The following is a description of a gene set: Cytokines mediate cell-cell communication in the immune system and represent important therapeutic targets. A myriad of studies have highlighted their central role in immune function, yet we lack a global view of the cellular responses of each immune cell type to each cytokine. To address this gap, the authors created the Immune Dictionary, a compendium of single-cell transcriptomic profiles of more than 17 immune cell types in response to each of 86 cytokines (>1,400 cytokine-cell type combinations) in mouse lymph nodes in vivo. A cytokine-centric view of the dictionary revealed that most cytokines induce highly cell-type-specific responses. For example, the inflammatory cytokine interleukin-1β induces distinct gene programmes in almost every cell type. A cell-type-centric view of the dictionary identified more than 66 cytokine-driven cellular polarization states across immune cell types, including previously uncharacterized states such as an interleukin-18-induced polyfunctional natural killer cell state. studied in species Mus musculus from publication Cui A, Huang T, Li S, Ma A, Pérez JL, Sander C, Keskin DB, Wu CJ, Fraenkel E, Hacohen N (PMID 38057668) Genes negatively differentially expressed in cell type: CD4+ T cell upon treatment with cytokine: IL-1β in mouse lymph nodes in vivo. Mouse Gene Set: CUI_T_CELL_CD4_IL1B_RESPONSE_DN, and this is the list of marker genes: Capg, Fam78a, Ass1, Bcl11b, Bin2, Adgre5 (adhesion G protein-coupled receptor E5), Tesc, Cnn2, Cd40lg, Pycard, Shisa5, Rasgrp1, Thy1, Srpk2, Dap, Stap1, Myl6, Tbc1d10c, Dipk1a, Tecpr1, Selenop, Ptprcap, Pdk1, Tox, Sh3kbp1, Rab37, Fmnl1, Filip1l, Lck, Cd6, Zbtb7b, Foxp1, Itgal, Hsd11b1, Prex1, Adcy7, Akr1b1, Smc4, Tspan32, Rgcc, St8sia6 (NCBI Gene Id 99126, ST8 alpha-N-acetyl-neuraminide alpha-2,8-sialyltransferase 6), Lcp1, Sh3bgrl3, Tagln2, Emp3, Saraf, Ramp1, 9930111J21Rik2, Mgst2, Cd96, Crip1, Lgals1, Evl, Tnik, Grap, Septin9, Lsp1, Ccdc88c, Limd2, Arhgdib, Cd28, Gpr174, Mxd4, Macf1, Nsg2, Cd3g, Ltb, Rac2, Fxyd5, Lcp2, Itgb2, Ms4a4b, Cd9 (CD9 antigen), Tecr, Rasgrp2, S100a10, Flna, Itpkb, Cd84 (NCBI Gene Id 320559), Cd5, Cd37, Tes, Asap1, Id3, Spn, Tubb5, Cotl1, Smpdl3a, Atp2a3, Anp32a, Dapl1, Rgs10, Cd52, Rhoh, Pdlim4, Bin1, Cfl1, Ms4a6b, Eno1, Septin1, Hvcn1, Cd27, Ankrd44, Chd3, Gpsm3, Cd247, Gm2a, Cd44, Trat1, Itga4, Klf2, Ahnak, Cd48, Arhgef1, Btg2, Lims1, Coro1a, Arrb2, Ift80, Apbb1ip, Fkbp1a, Themis, Trbc2, Tmsb10, Clec2d, Faah, Cd4, Itgb7, Pitpnc1